Given this list of marker genes Usp18, Ifi203, Dtx3l, Isg15, Tap1, Samhd1, Cmpk2, Phf11b, Tmbim6, Ifi35, Irgm2, H2-T22, Epsti1, Stat1, B2m, Ly6e, Eif2ak2, Trim25, Rigi, Slfn5, Zup1, Ccnd2, Slfn8, Ifi208, Psme2, Trafd1, Tapbp, Ifit3, Bst2, Psme1, Herc6, Trim12c, Lgals3bp, Ifi47, Oas3, Samd9l (sterile alpha motif domain containing 9-like), Selenow, Ly6a, Slfn1, Ifi27l2a, Sp100, Trim30d, Mndal, Parp9, Gbp9, Ifit1, Psmb8, Isg20, Ifih1, Mitd1, H2-T23 (histocompatibility 2, T region locus 23), Ifi206, Ifit3b, Ifi213, Slfn2, Oasl2, Ifi209, Zbp1, Shisa5, Rtp4, Trim30a, Irgm1, Ddx60, Irf7, Ddx24, Ppa1, Rnf213, Parp14, Rsad2, Ifit1bl1, Phf11c, Helz2, Xaf1, Ms4a6b, here is a description of the gene set: from publication Cui A, Huang T, Li S, Ma A, Pérez JL, Sander C, Keskin DB, Wu CJ, Fraenkel E, Hacohen N (PMID 38057668) Cytokines mediate cell-cell communication in the immune system and represent important therapeutic targets. A myriad of studies have highlighted their central role in immune function, yet we lack a global view of the cellular responses of each immune cell type to each cytokine. To address this gap, the authors created the Immune Dictionary, a compendium of single-cell transcriptomic profiles of more than 17 immune cell types in response to each of 86 cytokines (>1,400 cytokine-cell type combinations) in mouse lymph nodes in vivo. A cytokine-centric view of the dictionary revealed that most cytokines induce highly cell-type-specific responses. For example, the inflammatory cytokine interleukin-1β induces distinct gene programmes in almost every cell type. A cell-type-centric view of the dictionary identified more than 66 cytokine-driven cellular polarization states across immune cell types, including previously uncharacterized states such as an interleukin-18-induced polyfunctional natural killer cell state. Mouse Gene Set: CUI_T_CELL_GD_IFNK_RESPONSE_UP Genes positively differentially expressed in cell type: γδ T cell upon treatment with cytokine: IFN-κ in mouse lymph nodes in vivo. species: Mus musculus